Given this list of marker genes MBLAC2, RAB14, ATG12, RAB11FIP5, RHOH, NCAPH2, PEBP1, GRN, ARHGAP25, RNF130, SERAC1, KAT14, TUBGCP4, STOML1, TNFAIP8L2, ZBTB12, AP5S1, TIMP2, USF1, MTMR3, STX16, HASPIN, PDIK1L, CEP19, TWNK, CCDC115, EHMT1, C1orf43, TMEM140, ZNF692, SMUG1, WEE1, CYBC1, EXO5 (exonuclease 5), ORC2, NKIRAS2, COA7, MFSD12, PITHD1, MRFAP1L1, RAD54B, DCTN5, NMNAT3, NEK9, SMIM20, RCOR3, PIP4P1, ZNF124, STAT2, GID4, GZF1, GDI1, NFRKB, STING1, SKA2, UBTD1, SDHB, CNN2, CREG1, PAQR7, DYNC1LI2, C8orf58, POLR3G, ARL4C, SPRING1, APPL2, MED19, CHST14, KMT2E, INPP5B, PPCS, EXOC8, ZBTB45, AKIRIN1, GPR137B, RPP25L, SBSN, FCRL1, CAMK2G, C2orf69, ZNF623, GAN, TMEM87B, DOK1, ORMDL1, KIAA0232, LIFR, TRAPPC11, CPT1A, RIOX1, ORMDL3, CRKL, ZC3H8, MRPS2, KLC4, ARRB1, TRIM59, NSD1, OGFRL1, COX19, LMO2 (LIM domain only 2), FAM89B, TMX2, MBD4, ZNF740, DUSP6, ZRANB2, PRKAB1, IP6K1, MBP, MRPL57, MFAP3, AP3M2, MAFB, C16orf54, CDK20 (NCBI Gene Id 23552), NATD1, ATG16L1, ZBTB1, BRK1, RNF167 (NCBI Gene Id 26001), TUFT1, ERI2, GSN, EMC3, CERK, SLC66A1, NBR1, ATP6V1B2, C1orf74, MAPDA, BID, SDF4, CBR3, PHF23, APOBEC1, C19orf53, ZFP90, INIP, ZBTB42, THBD, LRRC75A, DIS3L2 (NCBI Gene Id 282696), CNR2, DHX8, ZNF770, ATP5ME, PLEKHB2, FLVCR2, HMBS, MAD2L1BP, C17orf75, UBOX5, PHOSPHO2, TOR4A, MRPL27, NDUFS8, PGLS, UFL1, ZSCAN25, ZBED3, HYCC2, VDAC1, RASSF2, THEMIS2, GINS3, WDR5B (NCBI Gene Id 54554), EPM2AIP1, BLVRB, LRRC45, LIPT1, PRIMPOL, SKP2, S1PR2, RHEBL1, TCTA, HIF1AN, GCFC2, LTO1, USP30, SESN1, PHLDA3, LGMN, RP9, CLK2, TRIM65, NHLRC3, MMS19, ZNF771, TMEM18, RSPH3, SS18L2, COTL1, MTMR10, ZNF322 (NCBI Gene Id 79692), FANCF, PPIB, MOAP1, DENND10, here is a description of the gene set: Genes up-regulated in comparison of unstimulated macrophage cells versus macrophage cells stimulated with LPS (TLR4 agonist) for 120 min. Human Gene Set: GSE14769_UNSTIM_VS_120MIN_LPS_BMDM_UP The innate immune system is a two-edged sword; it is absolutely required for host defense against infection, but if left uncontrolled can trigger a plethora of inflammatory diseases. Here we used systems biology approaches to predict and validate a gene regulatory network involving a dynamic interplay between the transcription factors NF-κB, C/EBPδ, and ATF3 that controls inflammatory responses. We mathematically modeled transcriptional regulation of Il6 and Cebpd genes and experimentally validated the prediction that the combination of an initiator (NF-κB), an amplifier (C/EBPδ) and an attenuator (ATF3) forms a regulatory circuit that discriminates between transient and persistent Toll-like receptor 4-induced signals. Our results suggest a mechanism that enables the innate immune system to detect the duration of infection and to respond appropriately. studied in species Homo sapiens from publication Litvak V, Ramsey SA, Rust AG, Zak DE, Kennedy KA, Lampano AE, Nykter M, Shmulevich I, Aderem A (PMID 19270711)